The following is a description of a gene set: Reactome Pathway: p75NTR regulates axonogenesis species: Homo sapiens p75NTR modulates axonal growth by regulating the activity of small GTPases like RHOA and RHOB, that control the state of actin polymerization. The best studied is RHOA. In its active, GTP-bound form, RHOA rigidifies the actin cytoskeleton, thereby inhibiting axonal elongation and causing growth cone collapse. Depending on the ligand that binds to it, p75NTR can either promote or inhibit axonal growth, Neurotrophin binding leads to inhibition of RHOA activity and axonal growth. Axonal growth inhibition is caused by myelin molecules named MDGIs (myelin-derived growth inhibitors), such as NOGO, MAG, OMGP. MDGIs bind to a complex made up of p75NTR and the NOGO receptor, causing RHOA activation and axonal growth inhibition. part of: p75 NTR receptor-mediated signalling, and this is the list of marker genes: RHOA, NGF, MAG, OMG, MCF2, LINGO1, RTN4 (NCBI Gene Id 57142), ARHGDIA (NCBI Gene Id 396), NGFR, RTN4R